The following is a description of a gene set: Human Gene Set: THAKAR_PBMC_INACTIVATED_INFLUENZA_AGE_70PLS_VS_21_30YO_0DY_UP studied in species Homo sapiens from publication Thakar J, Mohanty S, West AP, Joshi SR, Ueda I, Wilson J, Meng H, Blevins TP, Tsang S, Trentalange M, Siconolfi B, Park K, Gill TM, Belshe RB, Kaech SM, Shadel GS, Kleinstein SH, Shaw AC (PMID 25596819) To elucidate gene expression pathways underlying age-associated impairment in influenza vaccine response, we screened young (age 21-30) and older (age >= 65) adults receiving influenza vaccine in two consecutive seasons and identified those with strong or absent response to vaccine, including a subset of older adults meeting criteria for frailty. PBMCs obtained prior to vaccination (Day 0) and at day 2 or 4, day 7 and day 28 post-vaccine were subjected to gene expression microarray analysis. We defined a response signature and also detected induction of a type I interferon response at day 2 and a plasma cell signature at day 7 post-vaccine in young responders. The response signature was dysregulated in older adults, with the plasma cell signature induced at day 2, and was never induced in frail subjects (who were all non-responders). We also identified a mitochondrial signature in young vaccine responders containing genes mediating mitochondrial biogenesis and oxidative phosphorylation that was consistent in two different vaccine seasons and verified by analyses of mitochondrial content and protein expression. These results represent the first genome-wide transcriptional profiling analysis of age-associated dynamics following influenza vaccination, and implicate changes in mitochondrial biogenesis and function as a critical factor in human vaccine responsiveness. Genes up-regulated in peripheral blood mononuclear cell seniors vs young adults in seniors (70+), young adults (21-30) after exposure to Inactivated influenza vaccine, time point 0D, and this is the list of marker genes: ARL6IP1, LPAR6, REEP5, ITGB1, GBP5